The following is a description of a gene set: part of: Triglyceride metabolism studied in species Homo sapiens Reactome Pathway: Triglyceride catabolism Triacylglycerol is a major energy store in the body and its hydrolysis to yield fatty acids and glycerol is a tightly regulated part of energy metabolism. A central part in this regulation is played by hormone-sensitive lipase (HSL), a neutral lipase abundant in adipocytes and skeletal and cardiac muscle, but also abundant in ovarian and adrenal tissue, where it mediates cholesterol ester hydrolysis, yielding cholesterol for steroid biosynthesis. The hormones to which it is sensitive include catecholamines (e.g., epinephrine), ACTH, and glucagon, all of which trigger signaling cascades that lead to its phosphorylation and activation, and insulin, which sets off events leading to its dephosphorylation and inactivation.<p>The processes of triacylglycerol and cholesterol ester hydrolysis are also regulated by subcellular compartmentalization: these lipids are packaged in cytosolic particles and the enzymes responsible for their hydrolysis, and perhaps for additional steps in their metabolism, are organized at the surfaces of these particles (e.g., Brasaemle et al. 2004). This organization is dynamic: the inactive form of HSL is not associated with the particles, but is translocated there after being phosphorylated. Conversely, perilipin, a major constituent of the particle surface, appears to block access of enzymes to the lipids within the particle; its phosphorylation allows greater access. <p>Here, HSL-mediated triacylglycerol hydrolysis is described as a pathway containing twelve reactions. The first six of these involve activation: phosphorylation of HSL, dimerization of HSL, disruption of CGI-58:perilipin complexes at the surfaces of cytosolic lipid particles, phosphorylation of perilipin, association of phosphorylated HSL with FABP, and translocation of HSL from the cytosol to the surfaces of lipid particles. The next four reactions are the hydrolysis reactions themselves: the hydrolysis of cholesterol esters, and the successive removal of three fatty acids from triacylglycerol. The last two reactions, dephosphorylation of perilipin and HSL, negatively regulate the pathway. These events are outlined in the figure below. Inputs (substrates) and outputs (products) of individual reactions are connected by black arrows; blue lines connect output activated enzymes to the other reactions that they catalyze. <p>Despite the undoubted importance of these reactions in normal human energy metabolism and in the pathology of diseases such as type II diabetes, they have been studied only to a limited extent in human cells and tissues. Most experimental data are derived instead from two rodent model systems: primary adipocytes from rats, and mouse 3T3-L1 cells induced to differentiate into adipocytes., and this is the list of marker genes: FABP3, PPP1CC, PLIN3, FABP4, LIPE, FABP6, FABP12, CAV1, PLIN1, PNPLA5, FABP2, PPP1CA, FABP1, PRKACB, FABP9, FABP5, FABP7, PNPLA4, GPD2, MGLL, ABHD5, PRKACG, PPP1CB, PRKACA